The following is a description of a gene set: Genes predicted to be targets of miRBase v22 microRNA hsa-miR-203b-5p in miRDB v6.0 with MirTarget v4 prediction scores > 80 (high confidence targets). Human Gene Set: MIR203B_5P species: Homo sapiens from publication Chen Y, Wang X (PMID 31504780), and this is the list of marker genes: IPO7, KIAA1210, TENT5A, OSMR, KPNA3, NPR3 (natriuretic peptide receptor 3), TANC2, KRAS, FAM234B, MFSD14A, ZNF800, TMEM115, MMD, ANO5, KATNBL1, UBE2G2, GDAP1, TSSK2, CBLL1, RNF19A, SERTAD2, ARF6, CREB3L1, ARK2N, DYNC1I1, CTTNBP2, PHF6, AQP4, MAGI1, SORCS1, WBP1L (NCBI Gene Id 54909), KAT2B, HLA-F, ZHX1, UBE2V1, EGR2, RIMS1, ARL15, DYNC1LI2, CACNB2, PRKACB, VSIG1, TIPARP, KCNN3, GARS1, SUSD6, CNRIP1, MAN1A2, LHFPL2 (NCBI Gene Id 285713), ZNF223, LONRF1, CAPN1, RBSN, NPC1L1, CDK17, ABHD17B, EPB41L4B, CCNC, RYBP, CD2AP, TECRL, ABCC4, ZRANB1, ALDH6A1, UBA6, GLIPR1L2, CHD8, ADHFE1, CPT1A, HDAC7, CHCHD3, MTSS1